The following is a description of a gene set: Pyrimidine salvage studied in species Mus musculus Mouse Gene Set: REACTOME_PYRIMIDINE_SALVAGE, and this is the list of marker genes: Tk2, Upp2, Uck2, Tymp (thymidine phosphorylase), Pudp, Uck1, Tk1, Cda, Upp1, Dck, Uckl1